The following is a description of a gene set: Genes down-regulated in A549 cells (lung adenocarcinoma) upon SKIL knockdown by RNAi. Human Gene Set: ZHU_SKIL_TARGETS_DN SnoN is an important negative regulator of transforming growth factor beta signaling through its ability to interact with and repress the activity of Smad proteins. It was originally identified as an oncoprotein based on its ability to induce anchorage-independent growth in chicken embryo fibroblasts. However, the roles of SnoN in mammalian epithelial carcinogenesis have not been well defined. Here we show for the first time that SnoN plays an important but complex role in human cancer. SnoN expression is highly elevated in many human cancer cell lines, and this high level of SnoN promotes mitogenic transformation of breast and lung cancer cell lines in vitro and tumor growth in vivo, consistent with its proposed pro-oncogenic role. However, this high level of SnoN expression also inhibits epithelial-to-mesenchymal transdifferentiation. Breast and lung cancer cells expressing the shRNA for SnoN exhibited an increase in cell motility, actin stress fiber formation, metalloprotease activity, and extracellular matrix production as well as a reduction in adherens junction proteins. Supporting this observation, in an in vivo breast cancer metastasis model, reducing SnoN expression was found to moderately enhance metastasis of human breast cancer cells to bone and lung. Thus, SnoN plays both pro-tumorigenic and antitumorigenic roles at different stages of mammalian malignant progression. The growth-promoting activity of SnoN appears to require its ability to bind to and repress the Smad proteins, while the antitumorigenic activity can be mediated by both Smad-dependent and Smad-independent pathways and requires the activity of small GTPase RhoA. Our study has established the importance of SnoN in mammalian epithelial carcinogenesis and revealed a novel aspect of SnoN function in malignant progression. species: Homo sapiens from publication Zhu Q, Krakowski AR, Dunham EE, Wang L, Bandyopadhyay A, Berdeaux R, Martin GS, Sun L, Luo K (PMID 17074815), and this is the list of marker genes: CDKN2C, MYO18A, CCND3, TGFBR3, CCNA2, TJP2, CCNE2, EMP1, BIRC5